Given this list of marker genes SLC2A1, PHLDA1, SLC25A28 (NCBI Gene Id 81894), B3GNT2, MAK16, PPAN, IER2, EREG, TUBB6, NOP56, SRR, AK4, PTGES, DUSP6 (NCBI Gene Id 1848), NOPCHAP1, NOP58 (NCBI Gene Id 51602), BYSL, FOSL1, CDR2, TUBB2A, SPRED2, BHLHE40 (basic helix-loop-helix family member e40), SYNJ2, HMGCR, CCL7, CCL2, HMOX1 (NCBI Gene Id 3162), NOCT, SRXN1, SPSB1, here is a description of the gene set: We have employed microarray technology using RNA from normal 3T3-L1 adipocytes and from 3T3-L1 adipocytes made insulin-resistant by treatment with tumor necrosis factor-alpha to identify a new class of insulin-responsive genes. These genes continued to respond normally to insulin even though the adipocytes themselves were metabolically insulin-resistant, i.e. they displayed a significantly decreased rate of insulin-stimulated glucose uptake. Approximately genes/expressed sequence tags (ESTs) were screened. Of these, genes/ESTs were identified that became insulin-resistant as expected (e.g. Socs-3, junB, and matrix metalloproteinase-11). However, genes/ESTs continued to respond normally to insulin. Although some of these genes were previously shown to be regulated by insulin (e.g. Glut-1 and beta3-adrenergic receptor), other novel insulin-sensitive genes were also identified (e.g. Egr-1, epiregulin, Fra-1, and ABCA1). Real-time reverse transcription-PCR analysis confirmed the expression patterns of several of the differentially expressed genes. One gene that remained insulin-sensitive in the insulin-resistant adipocytes is the transcription factor Egr-1. Using an antisense strategy, we show that tissue factor and macrophage colony-stimulating factor, two cardiovascular risk factors, are downstream EGR-1 target genes in the adipocyte. Taken together, these data support the hypothesis that some signaling pathways remain insulin-sensitive in metabolically insulin-resistant adipocytes. These pathways may promote abnormal gene expression in hyperinsulinemic states like obesity and type II diabetes and thus may contribute to pathologies associated with these conditions. Genes up-regulated in 3T3-L1 cells (adipocyte) by insulin which continued to respond normally to insulin in the insulin resistant cells. Human Gene Set: SARTIPY_NORMAL_AT_INSULIN_RESISTANCE_UP from publication Sartipy P, Loskutoff DJ (PMID 14530283) species: Mus musculus